The following is a description of a gene set: Oxidation by cytochrome P450 Mouse Gene Set: WP_OXIDATION_BY_CYTOCHROME_P450 studied in species Mus musculus, and this is the list of marker genes: Cyp11b2 (NCBI Gene Id 13072), Cyp51, Cyp2e1, Cyp1a1 (NCBI Gene Id 13076), Cyp19a1, Cyp26c1, Cyp2s1, Cyp2u1, Cyp17a1, Cyp39a1, Cyp24a1, Cyp26b1, Cyp11a1, Cyp26a1 (cytochrome P450, family 26, subfamily a, polypeptide 1), Cyp46a1, Cyp7a1, Cyb5a, Por, Cyp4x1, Cyp1a2, Cyp7b1 (cytochrome P450, family 7, subfamily b, polypeptide 1), Cyb5r1, Cyp20a1, Cyp4v3, Cyb5r2, Cyp4f39, Cyp8b1, Cyp2f2, Cyp21a1, Cyp2r1, Cyp27b1, Cyb5r4, Cyp4f18, Cyb5b, Cyp11b1 (cytochrome P450, family 11, subfamily b, polypeptide 1), Cyb5r3, Cyp4b1, Cyp2w1, Cyp1b1, Cyp27a1